The following is a description of a gene set: Mouse Gene Set: GOBP_HEART_DEVELOPMENT studied in species Mus musculus The process whose specific outcome is the progression of the heart over time, from its formation to the mature structure. The heart is a hollow, muscular organ, which, by contracting rhythmically, keeps up the circulation of the blood., and this is the list of marker genes: Fat4, Tnfrsf1b (NCBI Gene Id 21938), Calr, Myo18b, Anks6, Kcnk2, Isl1, Map2k2, Myh7, Trp53, Vegfa, Dzip1 (NCBI Gene Id 67061), Setd2, Prkdc, Dchs1, Smg9, Abl1, Epor, Wnt3a, Smyd4, Ddx39b, Fzd7, Bmp4, Smyd2, Ank2, Bbs7, Adra1b, Fdps, Kdr, Foxh1, Trp53bp2, Matr3, Nat8f5, Ednra, Rara, Tnnc1, Arl13b, Olfm1, Odad2, Agtr2, Meis1, Lrrc10, Robo2, Npy5r, Lrp2, Hspb7, Sgcb, Dnah11, Gja6, Ccdc40, Lrrc25, Ilk, Tfap2a, T, Akap6, Oxt, Pcna, Sik1 (salt inducible kinase 1), Pi16, Ly6e, Ncor2 (NCBI Gene Id 20602), Hdac2, Fgf3, Nrap, Smarca4, Ece1, Pten, Flrt3, Cer1, Vcan, Emp2, Traf3ip1, Wnk1, Zic3, Fes, Met, Nr3c1, Dync2h1, Txnrd2, Dvl3, Nodal, Lmo4, Arrb2, Tpm1, Ift52, Pin1, Npy2r, Ppp1r13l, Prokr1, Pou4f2, Mir20a, Ctnnb1, Nrp2, Tert, Ltbp1, Ift88, Invs, Crkl, Acacb, Gaa, Spred1, Shc1, Ndrg4, Hnrnpu, Dctn5, Nppb, Itga4, Dhx36, Mb, Hes1, Tafazzin, Id3 (inhibitor of DNA binding 3), Mrtfb, Rtn4, Hopx, Ptk7, Kdm2a, Agt, Traf3ip2, Tbx19, Rxrb, Tgfbr1, Sh3pxd2b, Fzd1, Lemd2, Ptch1, Myocd, Dnaaf3, Zmpste24, Dvl1, Actc1, Cited2, Ppara, Atg7, Grhl2, Mbd3, Gli3, Ndufv2, Mbd2, Kat6a, Sox17, Wt1, Pax3, Col11a1, Ift20, Fgf20, Sufu, Nrg1, Pln, Zbtb14, Sav1, Kat2b, Rac1, Aldh1a2, Myl7 (myosin, light polypeptide 7, regulatory), Ripply3, Ascl1, Sec24b, Fgfrl1, Flna, Col14a1, Pdgfrb, Tnfrsf1a, Dand5, Nkx2-6, Dnai1, Slit2, Angpt1, Ext1, Map2k4, Ccn4, Tmem94, Gata3, Rbp4, Tmed2, Pdlim4, Prox1, Vcam1, Kctd10, Adra1a, Lox, Eva1a (eva-1 homolog A, regulator of programmed cell death), Egfr, Gja5, Sall4, Pkd2, Odad3, Mmp21, Nfatc3, Dnah5, Eng, Rnf207, Large1, Lix1l, Pdlim3, Ifitm2, Sfrp2, Cby1, Ctcf, Scn5a, Id1, Myh11, Slc8a1, Mir92-1, Atf2, Kcnq1, Bicc1, Alpk2, Cripto, Slit3, Ppp3cb, Foxc2, Prok2, 3425401B19Rik, Tab2, Pdpn, Wnt11 (NCBI Gene Id 22411), Jarid2, Fgf9, Sox18, Speg, Trp73, Mir1a-2, Efna1, Fhl2, Mapk3, Hoxa13, Ccdc39, Luzp1, Nprl3, Sgcd, Mef2c, Bvht, Abcc9, Parva, Cpe, Id2, Mir18, Cavin4, Nf1, Cimap3, Foxj1 (forkhead box J1), Col2a1, Lcn10, Tead2, Gata4, Sorbs2, Arid2, Cacybp, Ptpn11, Tgfb3, Tead1, Ptcd2, Fuz, Odad4, Gnaq, Psen1, Rpgrip1l, Lrp6, Mir1954, Adipor2, Alpk3, AW551984, Gata5, Jag1, Ihh, Gpc3, Dag1, Smyd1, Gng5, Trip11, Mixl1, Fgf1, Smad2, Calcrl, Rbm15, Ramp2, Hspg2, Ppp3r1, Jph2, Snai1, Zfp36l1, Il1a, Dkk1, Oxtr, Hamp, Ap2b1, Tgfb2, Adgrg6, Adamts6, Adprhl1, Inhba, Epo, Pde2a, Wnt16, Xirp2, Myl3, Agtr1a, Shox2, Dlc1, Nrp1 (neuropilin 1), Folr1, Pbrm1, Dnm2, Ift172, Hamp2, Rarb, Med1, Heg1, Rb1, Mapk11, Adm, Cntrl, Mir19b-1, Ift57, Ccdc103, Pdlim2, Pdlim5, Cluap1, Dipk2a, Sirt6, Wnt2, Map2k5, Dhrs3, Prickle4, Mthfd1, Drc1, Gja1, Creb1, Smarcd3, Grem1, Casp3, Epha3, Mir452, Slc9a1, Adamts9, Synpo2l, Irx4, Ang2, Foxp4, Trex1, Egln1 (NCBI Gene Id 66006), Csrp3, Tenm4, Acadm, Mosmo, Pdgfb, Dll4, Scx, Sox11, Adamts5, Sox9, Eomes (eomesodermin), Pim1, Cav3, Stk3, Mylk2, Mylk3, Stil, Sgcg, Gsk3b, Cacna1c, Sox4, Parp2, Rbm10, Pitx2, Chd7, Adrb1, Twist1, Camk2d, Col3a1, Shh, Ryr2, Mir19a, Foxl1, Rhoa, Daw1, Vangl2, Nfatc4, Mmp2, Vegfb, Nfatc1, Tbx2, Sirt1, Pdcd4, Pofut1, Emilin1, Edn1, Mesp2, Noto, Kat2a (NCBI Gene Id 76912), Foxp1, Hdac9, Rbpj, Adamts19, Aplnr, Mib1, Atm, Myod1, Pou4f1, Ptprj, Kcnj11, Bmp7, Snx17, Jmjd6, Tek, Bmp2 (NCBI Gene Id 98992), Mical2 (NCBI Gene Id 70877), Pcnt, Pdlim1, Pax8, Gab1, Mmp9, Erbb2, Bves, Zfpm1, Megf8, Stk4, Dsp, Dusp6, Msx1, Cdkn1a, Tbx3, Tnni3, Apc, Gm12610, Erbb3, Map2k3, Cxadr, Hand2os1, Bmp10, Myl2, Dvl2, Eln, Casp7, Rest, Adap2, G6pd2 (glucose-6-phosphate dehydrogenase 2), Ift140, Casp8, Trip10, Grk2 (NCBI Gene Id 11557), Mef2b, Nckap1, Apela, Uty, Cplane2, Galnt11, Smad1, Fgf2, Igf1, Asxl2, Zdhhc16, Ep300, Msx2, Dsg2, Myh6 (NCBI Gene Id 268746), Tcap, Gsk3a, Gna11 (guanine nucleotide binding protein, alpha 11), Nipbl, Mybpc3, Ttn, Pdgfra, Rgs2, Hectd1, Fgf15, Mmp13, Fgfr2, Mdm2, Mospd3, Mdm4, Pskh1, Rbm24, Axin2, Bmpr1a, Tbx20, Pkd1l1, Ccnd2, Dicer1, Asb2, Cplane1, Tgfbr3, Ntrk3, Hhex, Eef1ece2, Ndst1, Pin1rt1, Ccm2l, Cep290, Maml1, Mecp2, Erbb4, Col6a1, Naglu, Lefty1, Fkrp, Heyl, Foxc1, Klk1b1, S1pr1, Senp2, Cc2d2a, Plxnd1, Acvr1, Cdkn1b, Gjc1, Kif7, Mir133a-1, Akap13, Kdm6a, Mgrn1, Has2, Bcor, Nog, Ncoa6, Acvr2b, Lrp1, Sos1, Gata6, Stra6, Ace, Pds5a, Mir133a-2, Nox4, Fgf8, Th, Ift122, Gli2, Cxcr4, Smad4, Ift25, Prkar1a, Adam19, Nkx2-5, Htr2b, Med12, Cad, Tie1, Chrd, Fam114a1, Gper1 (G protein-coupled estrogen receptor 1), Ovol2, Nsd2, Fn1, Pak1, Itga3, Kdm6b, Mef2a, Adam15, Frs2, Mir208a, Rbm20, Tgfb1, Npy1r, Mtor, Arid1a, Dyrk1a, Rb1cc1, Tgfbr2, Atg5, Tmem100, Ift74, Hdac3, Hdac5, Plxna4, G6pdx, Nphp3, Sod2, Hand2, Cdc42, Hand1, C2cd3, Hey1, Ccm2, Tsc2, Rgs4 (NCBI Gene Id 19736), Sall1, Flrt2, Thbs1, Pkp2, Pcdha8, Rxra, Tbc1d32, Ahr, Nkx3-1, Apln, Adamts1, Robo1, Mir17, Mir143, Plec, Mesp1, Ephb4, Tbx1, Ankrd11, Zmiz1, Prdm1, Spry1, Pcdha9, Srf, Myh10, Mef2d (myocyte enhancer factor 2D), Ube4b, Ccnb1, Borcs8, Lmna, Ap1b1, Atf7, Hmga1, Six1, Tab1, Ryr1, Smad3, Cdk1, Tnnt2, Mapk14, Tomm70a, Fadd, Bmpr2, Eya1, Ldb3, Fkbp1a, Ncam1, Dll1, Sox6, Cert1, Irx3, Prkg1, Tbx18, Ctdp1, Sema3c, Mnat1, Zfp418, Greb1l, Gys1, Jun, Ski, Popdc3, Kif3a, Tsc1, Acvr1b, Vgll4, Mapk1, Sin3b, Asxl1, Nos3, Dnaaf1, Tmem65, Cfc1, Nedd4, Insr, Efnb2, Pcsk5, Tnni1, Rnls, Prickle1, Hif1a, Slc25a4, Yy1, Foxn4, Smo, Wnt5a, Yap1, Enpp1, Xirp1, Notch1, Tbx5, Popdc2, Fgfr1, Frem2, Acan, Notch2, Kcnj8, Ppard, Ccn1, Map2k1, Fhod3, Acvrl1, Mecom, Sypl2, Mterf4, Ankrd1, Smad6, Osr1, Dnaaf4 (NCBI Gene Id 67685), Wdr11, Itgb1, Fzd2, Gm572, Bmp5, Mir145a, Neb, 2810429I04Rik, Snai2, Hexim1, Nek8, Nebl, Pkd1, Lbx1, Smad7, Slc22a5 (solute carrier family 22 (organic cation transporter), member 5), Gli1, Sgcz, Prmt1, Nfix, Mks1, Fbn1, Actn2, Hey2 (NCBI Gene Id 30802), Rps6ka2, Tmem67 (transmembrane protein 67), Col5a1, Setdb2, Zfpm2, Pdlim7, Foxf1